The following is a description of a gene set: Mouse Gene Set: REACTOME_OLFACTORY_SIGNALING_PATHWAY Olfactory Signaling Pathway species: Mus musculus, and this is the list of marker genes: Or10g7, Or10g3, Or2t47, Or10x1, Or14j1, Or10h1b, Or4q3, Or1e1c, Or10s1, Or51e1, Or6f1, Or8k3, Or8u9, Or5k1b, Or13c3, Or4f17-ps1, Or2t29, Or4f4b, Or8b3, Or2w3, Or51e2, Or2w1, Or2l13, Or1d2, Or1n2, Or2f1b, Or4l1, Or6p1, Or4c12, Or5d14, Or7g27 (NCBI Gene Id 258249), Or9g20, Or8b3b, Or2f1, Or56a4, Or2j3, Or51d1, Gnal, Or8b56, Or11a4, Or14a260, Or10a49, Or2at4, Gng13, Or10h1, Or1e1, Or2t49, Or2a20, Or2t46, Or2t1, Or10j5, Or11h6, Or10g9, Or5p80, Or51ai2, Or4d2b, Or2t43, Or5k1, Or10h5, Or2a57, Or2a51, Gnb1 (guanine nucleotide binding protein (G protein), beta 1), Or1a1b, Or4f4-ps1, Or8d23, Or11h4b, Or10g9b, Or2b11, Or2c1, Or2t48, Or5al1, Or7d9